The following is a description of a gene set: Ionotropic activity of kainate receptors species: Mus musculus Mouse Gene Set: REACTOME_IONOTROPIC_ACTIVITY_OF_KAINATE_RECEPTORS, and this is the list of marker genes: Grik1, Dlg4, Grik2, Grik3, Grik4, Grik5 (glutamate receptor, ionotropic, kainate 5 (gamma 2)), Ncald, Calm3, Calm2, Dlg3, Calm1, Dlg1